The following is a description of a gene set: species: Homo sapiens Human Gene Set: HP_TYPE_E_BRACHYDACTYLY Type E brachydactyly In type E brachydactyly, shortening of the fingers is mainly in the metacarpals and metatarsals., and this is the list of marker genes: HDAC4, PDE3A, HOXD13, PTHLH, COL2A1